Given this list of marker genes Pik3cb, Map3k4, Rps6kb1, Rock1, Tnk2, Cfl2, Pik3cd, Wasl, Pkn1, Was, Rtkn, Pak3, Rhoa, Pik3ca, Pip4k2a, Iqgap1, Pik3r2, Mybph, Cfl1, Gna13, Rac1, Pfn1, Mapk10, Calm1, Rock2, Arhgdib, Cdc42, Diaph1, Rhpn2, Sh3rf1, Ppp1cb, Arhgdig, Iqgap2, Sra1 (steroid receptor RNA activator 1), Cit, Limk1, Arhgef1, Myl1, here is a description of the gene set: Mouse Gene Set: WP_G13_SIGNALING_PATHWAY G13 signaling pathway studied in species Mus musculus